Given this list of marker genes HTR3A, HTR2C, HTR1B, HTR2A, CHRNA10 (cholinergic receptor nicotinic alpha 10 subunit), HTR4, HTR3D, HTR1E, HTR3B, CHRNA9, HTR1A, HTR1F, HTR5A, HTR3C, HTR6, HTR7, HTR3E, HTR1D, HTR2B, here is a description of the gene set: species: Homo sapiens Human Gene Set: GOMF_SEROTONIN_RECEPTOR_ACTIVITY Combining with the biogenic amine serotonin and transmitting a signal across a membrane by activating some effector activity. Serotonin (5-hydroxytryptamine) is a neurotransmitter and hormone found in vertebrates and invertebrates.